The following is a description of a gene set: A process that is carried out at the cellular level which results in the assembly, arrangement of constituent parts, or disassembly of actin-based cytoskeletal structures in the cell cortex, i.e. just beneath the plasma membrane. Mouse Gene Set: GOBP_CORTICAL_ACTIN_CYTOSKELETON_ORGANIZATION species: Mus musculus, and this is the list of marker genes: Fhod1, Tln1, Rab13, Coro1c, Epb41 (NCBI Gene Id 52373), Rhoq, Cavin3 (caveolae associated 3), Rock1, Dlg1, Kcnc3, Epb41l2, Arf6, Tnf, Anln (NCBI Gene Id 97521), Racgap1, Vil1, Akap11, Plek (pleckstrin), Ezr, Cdk5, Plec, Fmnl1, Nckap1, Calr, Pdcd6ip, Fhod3, Pls1, Iqgap2, Epb41l1, Fmnl2, Ikbkb, Llgl1 (LLGL1 scribble cell polarity complex component), Iqgap3, Rtkn, Nckap1l, Rock2, Fmnl3, Llgl2, Ect2, Iqgap1, Epb41l3, Strip1, Ehd2